The following is a description of a gene set: species: Mus musculus Monoamine GPCRs Mouse Gene Set: WP_MONOAMINE_GPCRS, and this is the list of marker genes: Adrb3, Htr2b, Htr5a, Drd4, Adra2b, Chrm2, Adra1a, Htr6, Adra2c, Adra1b, Adrb1, Hrh1 (histamine receptor H1), Adra2a, Adra1d, Htr1d, Chrm3, Drd5, Htr1b, Chrm4 (NCBI Gene Id 12672), Htr5b, Htr2c, Htr4, Drd2 (dopamine receptor D2), Adrb2, Htr1a, Drd1, Chrm5, Drd3, Hrh2, Htr1f (NCBI Gene Id 15557), Htr7, Chrm1